The following is a description of a gene set: studied in species Mus musculus Mouse Gene Set: GOBP_LYMPHOCYTE_AGGREGATION The adhesion of one lymphocyte to one or more other lymphocytes via adhesion molecules., and this is the list of marker genes: Rac2, Jam2, Adam8, Stk10, Msn (NCBI Gene Id 97596)